Given this list of marker genes Grip1, Dlg4, Mov10, Dvl3, Macf1, Fzd4, Ntng2, Ntng1, Map3k13, Dvl1 (NCBI Gene Id 13542), Dvl2, Myo9a, Wnt5a, Mfsd2a, here is a description of the gene set: species: Mus musculus Any process that modulates the frequency, rate or extent of the process in which the anatomical structures of a neuron projection are generated and organized into branches. Mouse Gene Set: GOBP_REGULATION_OF_NEURON_PROJECTION_ARBORIZATION